Given this list of marker genes QRSL1, LMNB1, H2BP2, MIR130A, XRCC2, PYCR3, ADCY8, DYNC2I2, TPM4, SLC16A1, PHF11, NDUFB11, FANCA, RASL12, CD9, GPR89B, GSTO1, MRPS16, DCTPP1, PPP2R5D, UBE2NL, NICN1, DARS2, SLC38A10, UBA5, SARM1, CDKN2C, PRR23A, B3GNT5, EHD1, SELL, NFE2L2, ANTKMT, MRPS11, SNORD87, ISYNA1, TIMELESS, IFIT2, ANO10, SPDL1, GOLIM4, MED22, SHMT2, LMAN2, HMGCS2, EIF6, TMEM60, MAGED2, EME1 (NCBI Gene Id 146956), OXA1L, IKZF2, PSPH, UBIAD1, PSME3, SNX2, PDLIM1, DDAH2, FLOT2, SLC35G1, DPM2, AP1M1, ADAM5, ASB5, ALG3, TRMT1, MLEC, FBXO15, KIFAP3, MCRS1, EMD, H2BC14, GATD1, MGAT2, LRRC23, MIR363, RBM3, GNB2, HMGXB4, SNORD14E, COX20, SERPINI1, E2F3, RABEPK, TPD52L2, TOR2A, LEKR1, FLI1 (NCBI Gene Id 2313), STAMBP, CSTB, CENPS, PMM1, DHDDS, RFC5, PARP16, NAAA, COX8A, INCENP, H2AX, GM2A, TMEM107, STARD4, LPXN, PLCB3, NOC4L, TCEA1, HMGN2P6, SLC37A4, IQGAP1, BAG2, HIGD2A, NT5C2, PPP4C, DHRS4, RWDD1, FKTN, CMPK1, ESYT1, ELOF1, ATP8B4, MARCKS, RAB1B, COPS9, ABCB8, STRIP2, RACGAP1, RRP1B, ITPRID1, IFT22, GSTT2, BBS5, CDK4, here is a description of the gene set: species: Homo sapiens Human Gene Set: GSE21033_3H_VS_24H_POLYIC_STIM_DC_DN BACKGROUND: Dendritic cells (DC) play a central role in primary immune responses and become potent stimulators of the adaptive immune response after undergoing the critical process of maturation. Understanding the dynamics of DC maturation would provide key insights into this important process. Time course microarray experiments can provide unique insights into DC maturation dynamics. Replicate experiments are necessary to address the issues of experimental and biological variability. Statistical methods and averaging are often used to identify significant signals. Here a novel strategy for filtering of replicate time course microarray data, which identifies consistent signals between the replicates, is presented and applied to a DC time course microarray experiment. RESULTS: The temporal dynamics of DC maturation were studied by stimulating DC with poly(I:C) and following gene expression at 5 time points from 1 to 24 hours. The novel filtering strategy uses standard statistical and fold change techniques, along with the consistency of replicate temporal profiles, to identify those differentially expressed genes that were consistent in two biological replicate experiments. To address the issue of cluster reproducibility a consensus clustering method, which identifies clusters of genes whose expression varies consistently between replicates, was also developed and applied. Analysis of the resulting clusters revealed many known and novel characteristics of DC maturation, such as the up-regulation of specific immune response pathways. Intriguingly, more genes were down-regulated than up-regulated. Results identify a more comprehensive program of down-regulation, including many genes involved in protein synthesis, metabolism, and housekeeping needed for maintenance of cellular integrity and metabolism. CONCLUSIONS: The new filtering strategy emphasizes the importance of consistent and reproducible results when analyzing microarray data and utilizes consistency between replicate experiments as a criterion in both feature selection and clustering, without averaging or otherwise combining replicate data. Observation of a significant down-regulation program during DC maturation indicates that DC are preparing for cell death and provides a path to better understand the process. This new filtering strategy can be adapted for use in analyzing other large-scale time course data sets with replicates. Genes down-regulated in bone marrow-derived dendritic cellstreated by poly(IC): 3h versus 24h. from publication Olex AL, Hiltbold EM, Leng X, Fetrow JS (PMID 20682054)